Given this list of marker genes PSMC4 (proteasome 26S subunit, ATPase 4), PSMA5, PSMA1, COP1, CDKN2A, PSMD13, CCNE2, PSMB4, PHF20, PSMB7, PSMD8, CDKN1B, SEM1, PSMB2, ATM (NCBI Gene Id 8068), PSMD2, PSMD7, PSMB1, PSMB5, PSMC3, PSMA7, CCNA2 (cyclin A2), TP53, RPS27A, PSMA6, PSMC5, PSMA2, PSMA4, MDM4 (MDM4 regulator of p53), UBC, PSMD3, UBA52, UBB, PSMD1, PSMC2, PSMB6, PSMD14, ZNF385A, CCNE1, PCBP4, PSMD12, PSMC1, CDKN1A, CHEK2, CDK2, PSMA3, PSMD11, PSMB3, MDM2, CCNA1, ADRM1, PSMD6 (NCBI Gene Id 9861), PSMC6, here is a description of the gene set: part of: p53-Dependent G1/S DNA damage checkpoint Most of the damage-induced modifications of p53 are dependent on the ATM kinase. The first link between ATM and p53 was predicted based on the earlier studies that showed that AT cells exhibit a reduced and delayed induction of p53 following exposure to IR (Kastan et al, 1992 and Khanna and Lavin, 1993).<p>Under normal conditions, p53 is a short-lived protein. The MDM2 protein, usually interacts with p53 (Haupt et al, 1997 and Kubbutat et al, 1997), and by virtue of its E3 ubiquitin ligase activity, shuttles p53 to the cytoplasm and mediates its degradation by the ubiquitin-proteasome machinery. Upon detection of DNA damage, the ATM kinase mediates the phosphorylation of the Mdm2 protein to block its interaction with p53. Also, phosphorylation of p53 at multiple loci, by the ATM kinase and by other kinases activated by the ATM kinase, stabilizes and activates the p53 protein.<p>The p53 protein activates the transcription of cyclin-dependent kinase inhibitor, p21. p21 inactivates the CyclinE:Cdk2 complexes, and prevent entry of the cell into S phase, leading to G1 arrest. Under severe conditions, the cell may undergo apoptosis. Reactome Pathway: p53-Dependent G1 DNA Damage Response species: Homo sapiens